The following is a description of a gene set: from publication Chen Y, Wang X (PMID 31504780) Genes predicted to be targets of miRBase v22 microRNA hsa-miR-8080 in miRDB v6.0 with MirTarget v4 prediction scores > 80 (high confidence targets). Human Gene Set: MIR8080 species: Homo sapiens, and this is the list of marker genes: UBE2C, CFDP1, ZMYM2, TFRC, SACM1L, CXCL5, KCTD4, ZNF326, PRRC1, GPC3, TOP2B, GRIA2, CCNYL1, FERMT2, NR4A3, KCTD20, SORL1, AREL1, EIF4E3, GAREM1, ARL5A, HS3ST2, PPARGC1B, PAXBP1, GPR68, GABRB2, PCDH12, KLHL29, EPM2AIP1, PLIN1 (perilipin 1), PLXDC2, STK17B, ABCD3, PAFAH1B1, CXCL9, ZNF831 (zinc finger protein 831), PPIP5K1, LCA5, RHAG, HNRNPDL, NBEAL1, ZNF384, SUMO3, PPP1R15B, TNIK, MYBL1, GEN1, SNX20, C4orf46, ARK2N, CD163 (CD163 molecule), NPAS3, PSD3, MEIS2, AMMECR1L (AMMECR1 like), PLOD2, ADRA1A, LRRC3, CCDC14, KCTD9, RCHY1, SESN3, MARCHF8, PGM3, SAR1B, KLHL1, RAB12, SLC25A24, RSAD1, ASAP2, ASAH2B, STAG2, SYT1, DCDC2B, CIRBP, AAK1, CSE1L (NCBI Gene Id 1434), HDGFL3, HKDC1, IPMK, SMAD3, RELN, TMTC2, PSMA5, SLC25A46, SEMA4D, NFKBIZ, ME1 (malic enzyme 1), HOXD10, SUGT1 (NCBI Gene Id 10910), PRKAR2A, DAGLB, RAB30, WWC2, SSH3, IRAK1BP1, NSD1, MPZ (NCBI Gene Id 4359), TESK2, DEFA4, CCDC177, HRH4 (NCBI Gene Id 59340), TRAM1, NEGR1, TENM1, RPL31 (NCBI Gene Id 6160), MET, FAM120A, MFAP3, KDM4A, WDR17, DDX17, RNF168, SEPHS1, DIRAS2, NEMP1, CCDC170, FHIP2A, GNA13, CNTN4, USP12, ATE1, FBXO28, TCN1, MACROH2A1, CDK19 (NCBI Gene Id 23097), EBF3, GNG12, RHCG, FRS2, DISC1, RALA, MFAP3L, MTF1, DTD2, SLC7A14, AP1S1, NREP